Given this list of marker genes RHOD, RPL28, GSPT2, LONP1, MORC2, CTSA, UBXN1, SLC39A8 (NCBI Gene Id 64116), B3GAT3, WNT5A, TWIST1, TAF1D, CD2BP2, NCOR1, RPS21, PITX1, PRDX2, RETREG2, SPTAN1, VPS37C, CITED2, TACC2, CDK10, ZNF419, PNMT, CDKN1C, GADD45B, NOP53, GABARAPL3, JRKL, FLNC, DGKD, SIM2, SGK1 (serum/glucocorticoid regulated kinase 1), FN1 (NCBI Gene Id 2335), NEBL, AHNAK, TXNIP, ABCA5, AUTS2, CCDC69, DNAJB2, ZNF160, ZNF580, SYT17, EFEMP2, MAPK8IP3, INHA, CSPG5, ST3GAL6, MUC1, S100P, FTH1, PDLIM5, BMP2K, CYP1B1, TFEB, SOCS6, CEACAM1, RGS2, AASDHPPT, GTF2H1, HTRA1, HOXA10, E2F1, FGFR1, ATF3, P3H2, B4GALT1, SIDT2, FOXO3, BPGM, TP53I3, AEN, CRAT, SECTM1, WWC1, REC8, TCFL5, LAMP3, MEIS2, NR3C1, NAMPT, CLIC3, ASS1, CCNA1, FOSL2, GRB10, CEP57, SHMT2, RARRES1, PDXK, TUFT1, PSCA, SH2D3A, PPP1R15A (protein phosphatase 1 regulatory subunit 15A), DUSP1, NEFH, CD55, H2AC11, STC2, CRIP1, IGFBP3, AFF1 (NCBI Gene Id 83116), GAD1, MSLN, here is a description of the gene set: Genes with the high-CpG-density promoters (HCP) that were up-regulated in 1542-CP3TX cells (prostate cancer) compared to 1542-NPTX (normal prostate). species: Homo sapiens from publication Wang Q, Williamson M, Bott S, Brookman-Amissah N, Freeman A, Nariculam J, Hubank MJ, Ahmed A, Masters JR (PMID 17486081) Oligoarray analysis of a matched pair of prostate cancer and normal cell lines derived from the same radical prostatectomy specimen identified 113 candidate hypomethylated genes that were overexpressed in the cancer cells and contained CpG islands. Hypomethylation of wingless-related MMTV integration site 5A (WNT5A), S100 calcium-binding protein P (S100P) and cysteine-rich protein 1(CRIP1) was confirmed in the cancer cells by bisulfite sequencing. Treatment of the corresponding normal prostate epithelial cells 1542-NPTX with the DNA methyltransferase inhibitor 5-Aza-2'-deoxycytidine (5-aza-CdR) induced higher levels of mRNA expression and partial loss of methylation on these genes. Primary prostate cancers were tested using methylation-specific polymerase chain reaction. WNT5A was hypomethylated in 11/17 (65%) tumors, S100P in 8/16 (50%) and CRIP1 in 13/20 (65%). Bisulfite sequencing of a section of the 5' untranslated region (UTR) of WNT5A revealed that three CpG sites (15, 24 and 35) were consistently methylated (93%) in the normal cell line and normal tissues, but not in the prostate cancer cell line and eight primary prostate cancers. Multiple putative binding sites for the transcription factors SP1 and AP-2 were found adjacent to CpG sites 15 and 24. A putative c-Myb binding site was located within the CpG site 35. Anti-c-Myb antibody co-precipitation with WNT5A was methylation-sensitive in 1542-NPTX cells. It is likely that an epigenetic mechanism regulates WNT5A expression in prostate cancer. Human Gene Set: WANG_HCP_PROSTATE_CANCER